The following is a description of a gene set: species: Homo sapiens Human Gene Set: GNF2_BUB3 Neighborhood of BUB3 BUB3 budding uninhibited by benzimidazoles 3 homolog (yeast) in the GNF2 expression compendium Neighborhood of BUB3, and this is the list of marker genes: HNRNPC, MCM3, SNRPG, SRSF10, PSIP1, KPNB1, SNRPA, BANF1, NAE1, HNRNPF, PTGES3 (prostaglandin E synthase 3), RAN, SSBP1, RPA1, XRCC5, TP53, TARS1, BUB3, SNRPD3, PSMA5, PSMA3, PA2G4, IFT25, SMC3, CCT3, HNRNPA2B1, U2SURP, TCP1